Given this list of marker genes Rock1, Il18, Ppp3ca, Rock2, Klf6, Tmbim1, Hrg, here is a description of the gene set: Any process that activates or increases the frequency, rate, or extent of tissue remodeling. Mouse Gene Set: GOBP_POSITIVE_REGULATION_OF_TISSUE_REMODELING species: Mus musculus